Given this list of marker genes OSBPL9, ELAC1, TTF2, ZMAT4, DYNC2LI1, EYA3, CCDC90B, TMCC2, AMIGO1, CEP162, GABPB1-IT1, WDR19, ILRUN, NR2E1, PORCN, CYYR1, BFSP2-AS1, AMZ2, BGN, SEMA4A, TMEM255A, PGLYRP2, KATNAL1, CD8A, ATG4D, BEGAIN, GSN (gelsolin), ZNF107, CMTM6, TNFRSF13C, CHD9, FAM220A, MRPL36, MORC3, ZCCHC4, CBLN1, NME1, EPHB6, MRPS15, SLITRK1, RPRM, CHD1, HNRNPDL, ISYNA1, KLHL41, DLC1, MRPL18, AURKAIP1, MFSD1, PHIP, ATG2A, ITGB1, ZBTB5, CUL9, CAND1, MYL12A, NEIL1, LARP1, HS1BP3, LACTB, BPIFA1, ZNF566, SAV1, TSLP, ARG1, C19orf73, FMN1, TMEM97, ZNF264, PYGB, MAGED4B, FBXO11, WDR46, REPIN1, CCBE1, ITK, LYZ, NUTM2F, NFIL3, SLC26A8, MOCOS, CDH5, PRDM1, EPS15L1, RNASEL (ribonuclease L), ERVMER34-1, MREG, SOX6, YWHAB, RBM7, LRP3, LYL1, AGAP2, CYP1A1, ZNF143, FABP2, CLCF1, GEMIN7, KLHL4, MBD5, EREG, COPE, PIP4K2C, SMG7 (NCBI Gene Id 9887), NCOA7, PTPRT, GRAPL-AS1, MCTS1, MST1R, HOMER2, FAIM, TFPI2, MRPL27, WDR25, ART3, PRDM8, CORIN, SP140L, ASXL2, C1orf116, UGCG, CCDC81 (NCBI Gene Id 60494), FLJ13224, SLC19A1, PLGLB2, QSER1, GPSM3, ACVR1, LEPROTL1, CTSZ, TMED3, CIP2A, MOB4, LRRN3, KLHL36, EFCC1, FAF1, S100A5, PDCD6, PNMA8A, MXRA8, FAR2, TMEM250, MED28, WRNIP1, TMEM248, CHST9, LY9, TLN1, SCD, CDH22, CELP, RPAP3, SCARA3, CHL1, RNF213, MMP14 (NCBI Gene Id 4323), ACKR1, DIRAS2 (NCBI Gene Id 54769), BCL2L13, MAPKBP1, FOS, PTPRF, KRT19, TIMP4, PLEKHM2, AMOTL2 (angiomotin like 2), IL1R2, NELFB, KIAA2013, SENP1, ANKRD13A, SIPA1L3, ELOVL2, LAP3, LRRC19, DCLK1, NXPH4, BCR, ARHGAP20, NUP58, CD1D, SPMAP2, SLMAP, SMAD3, OR7E12P, TMLHE, NGF, MMP9, MCMBP, PITPNC1 (NCBI Gene Id 731962), TBC1D8B, FUCA1, AASS, ANXA1, CCDC134, ALKBH4, ARHGAP45, CCL11, MAL2, EARS2 (glutamyl-tRNA synthetase 2, mitochondrial), ABI3, BAIAP3, SURF6, PIF1, TMEM120A, RRAGD, CELF2, ATXN7, SLAMF7, CSF2RB, PDE4D, HIF1A, VNN1, CEBPZ, DCTN3 (dynactin subunit 3), PDCD2L, GJC2, CDK16, APTX, ESPN, SDC3, TRIM7, ERLIN2, PTGS2, MLYCD, TIMELESS, CYP2A7 (NCBI Gene Id 1549), NOL7, EIF2B4, TRIM48, TMEM161A, DEXI, KDM4D, RNASE6, IL1A, MAP2K6, FNBP4, ACSM5, CSF1, MPRIP, DNAH11, FGD6, ZFP41, EPCIP, ATG16L1 (autophagy related 16 like 1), OXGR1, TESPA1, UFSP2, NOP53, RNF220, SNRNP25, GPATCH3, C17orf75, NCF2, SLC43A1, DZIP3, INIP, BRIP1, POU6F2, CD163, OTOR, XPO4, ZMYM5, OR2A1, TMEM47, GEM, COQ8A (NCBI Gene Id 56997), EPHA7, DCANP1, ZDHHC2, LMTK3, CCAR2, MICB, BAG3, OBSCN, NACAD, MED12L, LRRC14, SFRP1, PPP4R2, EEF1D, ATP8A2, CD1A, FN1, REV3L (REV3 like, DNA directed polymerase zeta catalytic subunit), PCGF1, DNAJA1P5, ZKSCAN7, FGFR1, CXCL10, NSUN3, TAL1, SLC17A8, UNC79, STAT3, DPYD, DES, VIT, TRABD, FAM169A, MMP7, MRPL47, CHST1, QKI, ZNF318, ACTR6, SQOR, HACD1, PAPOLA, ARHGAP15, HMGN5, SV2B, LRRC4C, MED25, GOLGA5, ZGRF1, PAWR, TDP1, SPNS1, AMY2B, NECAP2, IPCEF1, KATNIP, BTN2A1, CST1, CDH4, ABHD17C, ATRN, PYCR3, DDX60, GLB1L, PAQR5, DIO3, CCNL1, STAMBPL1, ERMN, IL18R1, ADIPOR2 (NCBI Gene Id 84751), NELFCD (negative elongation factor complex member C/D), NRL, MAPK4, LNPK, ITGA4, BRAP, FURIN, LANCL2, BCL2L14, PHAX, TMEM144, KDM5B, NANS, HIVEP2, ACE, SPSB4, TUBA4A, PLEKHF2, XRN2, CCL2, STRIP2, SLC22A3, AKAP8L, GPR68, AHNAK, SARAF, SSBP4, COL6A3, KCNE4, GPR26, HBE1, CDK11A, DCAF15, PI4K2B, IL1RL1, RERE, SH2B3, FBXW4, INO80B, CXCL8, TMEM62, COCH, PRPF39, EPB41L4B, POLDIP3, NEPRO, SLC11A2, RNF103, BSDC1, CACNA2D3, STRN (striatin), CNOT6L, CLUH, ANKFY1, SUGP2, TMEM121B, GOLGA4, UTP11, ITGB5, KAT2B, MICALL1, TP53, PARS2, SLC25A27, DNAAF4, PCED1B, ACSL1 (NCBI Gene Id 91249), GJA1, SIAH1, ALG6, ZNF117 (NCBI Gene Id 7670), PTPRZ1, LDAH, TOR4A, LY86, ITM2C, TBC1D9, MTMR12, TRIM14, SNX5, POGLUT2, FPR2, LINC00160, CCDC85C, PKIA, USP36, TMT1A, PLEKHG1, NUP54, ELOB, CITED2, PPP1R14D, GJA5, ITGAM, NADSYN1, BASP1, ARID5A, here is a description of the gene set: studied in species Homo sapiens Genes in the cancer module 378. Human Gene Set: MODULE_378